The following is a description of a gene set: Constitutive Signaling by AKT1 E17K in Cancer Human Gene Set: REACTOME_CONSTITUTIVE_SIGNALING_BY_AKT1_E17K_IN_CANCER species: Homo sapiens, and this is the list of marker genes: RICTOR (NCBI Gene Id 253260), CREB1, MTOR, CDKN1A, MDM2, CASP9, BAD, FOXO3 (forkhead box O3), FOXO4, PDPK1 (NCBI Gene Id 5170), AKT3, GSK3A, GSK3B, MAPKAP1, AKT1, AKT2, TSC2, FOXO1, AKT1S1, CHUK, NR4A1, MLST8, PRR5, RPS6KB2, CDKN1B, FOXO6